The following is a description of a gene set: Promoter methylation of the mismatch repair gene plays a key role in sporadic microsatellite instability (MSI) colorectal cancers. However, promoter methylation often occurs in proximal colon cancers, and molecular phenotypes underlying MSI cancers in distal colon have not been fully clarified. Our goal was to clarify the difference between MSI and microsatellite stability (MSS) cancers and, furthermore, to determine distinct characteristics of proximal and distal MSI cancers. By DNA microarray analysis of 84 cancers (33 MSI and 51 MSS), we identified discriminating genes (177 probe sets), which predicted MSI status with a high accuracy rate (97.6%). These genes were related to phenotypic characteristics of MSI cancers. Next, we identified 24 probe sets that were differentially expressed in proximal and distal MSI cancers. These genes included promoter methylation-mediated genes, whose expression was significantly down-regulated in proximal MSI cancers. Among discriminating genes between MSI and MSS, nine methylation-mediated genes showed down-regulation in MSI cancers. Of these, 7 (77.8%) showed down-regulation in proximal MSI cancers. Furthermore, methylation-specific PCR confirmed that frequency of hMLH1 promoter methylation was significantly higher in proximal MSI cancers (P = 0.0317). These results suggested that there is a difference between proximal and distal MSI cancers in methylation-mediated influence on gene silencing. In conclusion, using DNA microarray, we could distinguish MSI and MSS cancers. We also showed distinct characteristics of proximal and distal MSI cancers. The inactivation form of hMLH, per se, differed between proximal and distal MSI cancers. These results suggested that distal MSI cancers constitute a distinct subgroup of sporadic MSI cancers. Human Gene Set: WATANABE_COLON_CANCER_MSI_VS_MSS_DN from publication Watanabe T, Kobunai T, Toda E, Yamamoto Y, Kanazawa T, Kazama Y, Tanaka J, Tanaka T, Konishi T, Okayama Y, Sugimoto Y, Oka T, Sasaki S, Muto T, Nagawa H (PMID 17047040) Down-regulated genes discriminating between MSI (microsatellite instability) and MSS (microsatellite stability) colon cancers. species: Homo sapiens, and this is the list of marker genes: GPR15LG, BRD3OS, CHP2, NME7, TNMD, PPP1R14C, DUOX2, IGF2, CEL (carboxyl ester lipase), DACH1 (dachshund family transcription factor 1), TM2D1, HMGCS2, CYP2B6, ACE2, MGC32805, FREM2, SPINK1, VAV3, PDK3, MUC12, SLC39A5, ARL11, C3orf85, CXCL14, PTCD2, RNU6-82P, GPS2, TMEM106B, GNG4, KRT20, ZMYM2 (NCBI Gene Id 7750), WIF1, STAT5B, MAP3K12, GPR143, MYEF2, EMILIN3, SLC35D3, ACSL6, IGF1R, MUC20, TMCC1, SLC26A3, LY6G6D, SPIN3, GPSM2, KRT23, REEP1, SHROOM4, CDHR1, MAB21L3, SLC1A7, SEMA5A, CRIPTO, CFTR, FABP1, GRM8, RUBCNL, SLC26A2, CADPS, PCP4, POLR3E, OLFM4, A1CF, ISX, CELP, USP53, CBX5, MAP7D2